Given this list of marker genes POLR3K, COQ5, MIR4512, PDCD6IP, STX16, CDKN2AIPNL, DSP-AS1, BPHL, DBNL (drebrin like), TOM1L2 (target of myb1 like 2 membrane trafficking protein), SNHG12, LARS1, ARRDC2, ZNF410 (NCBI Gene Id 57862), MRPS31P5, PLAUR, SNHG7, USP30, GRPEL2, DISC1, RPS13, ZNF391, GAP43, ZNF569, HIRA, HCG20, AGPAT3, MBLAC2 (metallo-beta-lactamase domain containing 2), POLR1HASP, DYM, EIF2B3, TOMM22, H3C9P, SREBF1, SVIL, CFAP298, MAP3K9-DT, ITGB3BP, SNHG11, UIMC1, PCOLCE2, DHX8, ST6GALNAC2, SYT14, PDZD7, LEO1, ZNF740, EIF1AD, HEXA, LGALS8-AS1, AFMID, TMED2, QRICH1, PIK3IP1-DT, SMG5, EXOC8, ZNF546 (zinc finger protein 546), BMS1P4-AGAP5, DMGDH, DENND2C, UCHL5, LINC00663, SAMD4B, ZNF165, RNVU1-6, TIMM50, ABHD12, RBL1, ENTPD1-AS1, FAAP100, SMG7, SPEF2 (NCBI Gene Id 80192), MARK4, HTR5A (5-hydroxytryptamine receptor 5A), ZNF30-AS1, HSPD1, SLC25A16, CSRNP3, UBAP2, ZNF425, OGT, SMIM10L1, MDC1, SDHAF1, SRMS, CCDC159, SCP2, SNUPN, INO80B-WBP1, RAB11A, COPA, METTL15, SIRT2, METTL17, MTOR, AP3S2, RUFY1, EIF4E2 (NCBI Gene Id 9470), KAZN, RPL37 (NCBI Gene Id 6167), ZCWPW1, WDR70, PPP2CB, H3P41, GTF3C3, APOBEC3B, CALM3, KAT7, SVOP (SV2 related protein), LINC01409, LINC00665, IGDCC4, FANCL, NCSTN, RPS7, MAP3K21, PSMB3, MRPS33, ZNF30, RNF207, ZNF408, LGALS3BP, FAM229B, TTC23L-AS1, HPGD, TIMM29, MIR762HG, INO80B (NCBI Gene Id 83444), CDK5RAP3, UBE2I, ZNF490, INKA2, ENSG00000261335, STK38L (NCBI Gene Id 23012), KRBA1, IFT80, ELF1, CRKL, ABCA15P, DAAM2, ST13, EMX2OS, CSTPP1, HAUS5-DT, ICE1, SMC4, ZNF850, SELENOH, SLC33A1, THADA, FAXDC2, PRKACA, GNB2, EXO1, GLI1 (NCBI Gene Id 2735), COX16, ELAPOR1 (endosome-lysosome associated apoptosis and autophagy regulator 1), SNRNP35, FOXP2, TCHP, LUC7L, POLR2I, ENSG00000249295, SNORD3A, PDXDC1 (NCBI Gene Id 23042), XPNPEP3 (X-prolyl aminopeptidase 3), NOLC1, KRT75, EPB41L4A-AS1, TSPEAR-AS1, GABPB2, SMAD7, NDUFC2-KCTD14, MROH8, PHRF1, HMGN4, HEXIM2, CATSPERD, GDF15, ZC3HC1 (zinc finger C3HC-type containing 1), JAKMIP2, STMP1, HSPE1-MOB4, SUGCT, LINC01970, PBK, MIR7-3, IFT56, LUC7L2, IL17RC, SCARNA2, GUCD1 (guanylyl cyclase domain containing 1), SLC29A2, WDR26, DM1-AS, ANXA2R, TCF12, ISYNA1, UBB, DUSP6, ADRA1A, RPS15, PPP1R37, RNASE4, MRPL16 (mitochondrial ribosomal protein L16), MT-TW, C12orf76, MIR7-3HG (MIR7-3 host gene), RBM28, GNPAT, OXLD1, LMAN2, RNU6-841P, MIR5188, FRA10AC1, TRAK1, ENSG00000232995, MTR, UQCC3, GINS1, ZNF568, TLCD3B, ZNF350, LIPH, ZNF557 (zinc finger protein 557), SFSWAP, NOP58, SIL1, CCDC174, MED18, TVP23B, B3GALT4, SNRPD3, TMEM202-AS1, C19orf47, KNTC1, LYPLA2, CASTOR3P, ATOSB (NCBI Gene Id 80256), RPL6, BMS1P4, UBA2, GJC1, SCAMP3, HMGXB3, SPRED2, WDR36, UBP1, ADSL, ZNF233, HRCT1, NHSL1, COMMD2, CALM1, POLR1H, TOB2, SRA1, CBR3, TOX4, TRIM41, MAP2K5, TEX38, STUM, PCLAF, ENSG00000274248, ZNF829, HLA-DPB1, CELF1, FN3KRP, SH3BP1, ANKRD13A, DENND4A, VTRNA1-1, RNA5SP21, ADAMTS6, C2CD2L, SPRED1, IGFLR1, CD8A, ZNF45-AS1, PLEKHM3, EML2, ZFP41, GPBP1L1, SDHAP3, TLCD1, EIF2D, TLK2, ZNF284, MBTPS2, GET1, GAPDHP22, RESF1, FRG1HP, PRIM1, FZD1, KRTAP9-12P, ATP5MF-PTCD1, RAD50, COPS4, ISLR2, SPTBN4, GPATCH4, MYCBP2, C6orf89, SREK1IP1, PDE6D, OBSCN-AS1, EMG1, FMC1-LUC7L2, TSC22D4, RUVBL1, PLXDC2, GFER, NFIA-AS1, ECI1, POLR3G, PIN4, CDC123, MIR4515, NCEH1, RPTOR (regulatory associated protein of MTOR complex 1), SNHG29, ZFP30, GYS1, BACE1, STX16-NPEPL1, DNLZ, GBA1, MUC1, ALDOA, PTCD1, MRPS31, ABCB9, PDCD7, LRRC49, ZFP37, NDUFB7, HSD17B6, CAPNS1, TATDN2, SLC39A3, UBE2Z, SULT2B1, BACH2, TUBE1, HMGB1, BNIP1, ST3GAL5, CORO7, TDRD7, SNRPE, DENND2B, HJV, ZNF35, ARHGAP32, SNORA13, ASCC1, PLPP6, ZMIZ1, ZSCAN25, BLOC1S2, SF3B6, ZNF45, NDUFAB1, PRR16, PTGES3, NUP107-DT, KANTR (NCBI Gene Id 102723508), CPEB1, RAB2B, RNVU1-34, MRPL30, NBDY, DHPS, TUBGCP6, HEXIM2-AS1, TSEN15, STAT2, ZNF566-AS1, GFM1, COPS7B, THAP10, DHX16 (DEAH-box helicase 16), OSGEPL1, AGFG2, PLAU, SNRNP25, RRAS, AAR2, TMEM222, ZNF570, KRTAP10-8, NEMP1, DHRS4-AS1, COX7A2, WDR11-DT, VPS36, JMJD1C, KMT2B, ELK4, VARS2, RNF185, TPBGL, ATPAF1, ZNF268, ZNF808, LASP1, DDX56, CPNE8, SNORA50C, ZNF862, MEPCE, AKT3, LINC00265 (long intergenic non-protein coding RNA 265), ICA1, TSPAN12, ISOC1, RBBP5 (NCBI Gene Id 5929), ACVRL1, TRIP4, PPP5D1P, DAP-DT, AGK, KRR1, BAK1, GOLGA3, RARS2, SNHG17, GNG4, SCAF11, SNW1, CCNC, PCBP2, TBCD, GTF3C5, GDF5, ADAMTSL4-AS1, SCGN, EXOC3L1, E2F6, SPAG7, ENSG00000249236, RHBDF1, EIF3A, SNHG4, EPCIP-AS1 (EPCIP antisense RNA 1), DNAJC25 (NCBI Gene Id 548645), SEPTIN7P1, NOXA1, HSPE1, KIAA1671, KCTD5, NABP2, PAM16, MRPS2, B3GNTL1, NUP107 (NCBI Gene Id 57122), KRTAP5-5, PPCDC (NCBI Gene Id 60490), GRB2, MTND6P4, FAM230G, BANF1, PIK3IP1, PXMP2, FOSL2, TRAPPC8, HINT3, CCDC18-AS1, LINC01719, FLOT1, CASP8, MTND5P11, HYCC2, S100A2, GAPDHP14, DOHH, ZFP14, ODAD4, ARIH1, HLA-DMA, MT1X, SNORD84, UBASH3B (ubiquitin associated and SH3 domain containing B), AQR (NCBI Gene Id 9716), LNCTSI (NCBI Gene Id 128193292), NEK2, ZBTB41, TOMM20 (translocase of outer mitochondrial membrane 20), HNRNPA1, ATP5MC2, ST7, KDM5C, KRT89P, ZFYVE9, ENSG00000258471, C16orf95-DT, CCNL1 (cyclin L1), NME1, MPG, LIN54, C19orf44, MT-CO1, STING1, PRKAB2, DNAJC6, RHOQ, EXOC2, AXDND1, TSSK6, IDI1, ORC3, NME1-NME2, SNAP47, SLX9, CIRBP, ENC1, FHL1, EPS8, CSNK1E (casein kinase 1 epsilon), NIF3L1, ENSG00000260288, GBA1LP (glucosylceramidase beta 1 like, pseudogene), NAT1, SH3YL1, TIPRL, ADNP, PSMD3 (proteasome 26S subunit, non-ATPase 3), SNORA21, OGFOD2, ZBTB40, MRPS31P4, JTB, LBHD1, LINC00339, HDAC2-AS2, STX18, YKT6, LINC01275, LINC02454, SRRT, RPL36P5, TTC33, STAT6, DCAF8, EIF3K, KIAA2013, ABHD2, NDUFA13, TMEM259, RNU6-843P, MAF1, PRKCE, RPS6KA1, TPST1, CTNNB1, TM2D1, KBTBD4, SEC16B (SEC16 homolog B, endoplasmic reticulum export factor), METTL25, DSTYK (NCBI Gene Id 353293), HNRNPD, SERTAD3, MAPK4, TMEM79, MRPL39, FOXD3-AS1, CDC73, JMY, SLC39A2, DONSON, ATP5MC3 (ATP synthase membrane subunit c locus 3), CANX, ETFBKMT, CNNM2, MRPS15, SLC7A11, HAUS5, MED23, DHX37, CSAD, DNM1L, ATAD5, MROH2A, TMCC2, ASCC2, SSBP2, DUS1L (NCBI Gene Id 64118), DLEU1, KCNJ4, TMEM101, CCDC59 (coiled-coil domain containing 59), JTB-DT, CLIP1, LAMP1, IGF1R, RPL18P10, RPL27, UBE3D, BRD2, IFNAR1, CCT6B, BAG6, CCDC144BP, CDK11A, DSP, SH2B1, NDUFV3 (NCBI Gene Id 4731), CSNK1D, TRD-AS1, LINC03067, SLC19A2, HBS1L, ARMH3, CEBPA, DCLK1, MT-TQ, ST6GALNAC6, MCM3, GSTCD, NUP133-DT, GPI, FNDC11, TRAJ31, SMIM8, BCRP2, ZNF224, ACLY, KRBA2, INO80C, RTL8B, TRAV5, TMEM242-DT, IRGQ, PRKCH, NDUFB3, ATRIP, MIR5087, CSDE1, CMPK1, ARID1A, KANSL3, OSBPL7, TRIB1 (tribbles pseudokinase 1), HNRNPU, BAG2, LZTS2, LINC02831, DR1, MAD2L1, ATG4C, BNC2, SMAD9, KICS2, BEST3, RPS29P16, MAN1C1, RNF43, ZNF74, IFI6, RNU5A-1, IPO4, CLCC1, AFF1 (NCBI Gene Id 83116), GTF2IP20, RNU5D-1, ATG5, SLC25A21, SLC22A4, FAM133B (NCBI Gene Id 257415), SPRY1, CCDC77, KDM3B, PSMC1, MYOF, WARS1, WDR37, TAX1BP1-AS1, ZNF791 (NCBI Gene Id 163049), SLC1A3, EPRS1, PPP1R8, UBC, CBR3-AS1, TNK2-AS1, CREB3L2-AS1, UBQLN4, ENPP3, UGGT1, RMND1, KDSR, TWF1P1, RGS5, SFT2D1, GNAL, SLC35B4, NCOA7, TRMT13, CFDP1, USP54, NOL7, KHDC1, DTWD1 (DTW domain containing 1), H4C8, CENPW, PRPF39-DT, TNPO2, TPI1P2, WDR25, SYBU, WRAP53, ABR, PHF12 (NCBI Gene Id 57649), RN7SL346P, UBOX5, FANCD2, CPXM2, R3HCC1, GTPBP3, ZNF609, PEX13, EXOSC3, KANSL1, MYO19, STAT3, TTC7A, TAOK1, FAM174B, RPL23, DNAJC25-GNG10, ZNHIT3, RPL36AP13, LINC01623, NUDT15, SLC44A1, GIN1, GORASP2, RBM39, TRIM52-AS1, PIGL, ENSG00000263280, ATG7 (NCBI Gene Id 105376952), TOLLIP, MLLT6, SNORD49B, ADSS2, ISG20, SHARPIN, ZNF566, ABCA4, SCAMP2, RN7SKP114, MARCHF8, LINC00910, CCDC69, SNORA16A, STX18-AS1, RNU5B-1, CYP2S1, CXCR4, PCBP3, TMEM41A, SPRYD7, RAB37, FEM1A, LINC01559, TTC23L, MAST2, VPS29, TATDN3, NDUFS3, PPIP5K2, COASY, ZNF181, MTERF4, PEMT (NCBI Gene Id 10400), UNC5B, DYNLT4, BHLHE40-AS1, GINS4, MCAT, SSTR5-AS1, ZNF282, APOA1-AS, CD81-AS1, NMNAT1, RAI14, BTBD1, TBC1D13 (TBC1 domain family member 13), DUSP14, ADRM1, PPIL3, ZNF674-AS1, ETNK1-DT, KSR2, EXD3 (NCBI Gene Id 54932), ENTPD6, CALR3, EIF2AK3, HDAC5, HP1BP3, RPA2, ABRACL, PLEKHG5, LINC02366, ARHGEF1, RCAN1, WSCD1, RINT1, SASS6, NDUFS7, MRPL1, AARS2, PCID2, BLOC1S1, RFFL, TIMM44, NEK8, GNLY, EFL1P1, SNAPC5, MSTO2P, SRSF4, RCOR3 (REST corepressor 3), HNRNPD-DT, DHRS13, MNS1, CHD3, PHGDH, SNORD118, CAAP1, MITD1, MT-ND4L, MATR3, SLC25A23, AHCYL1, DEPP1, PCCA, MIR1273C, GIHCG (NCBI Gene Id 100506844), TRIM52, VIRMA, TRAPPC9, LRP4-AS1 (NCBI Gene Id 100507401), PSMD8, DMAP1, TMCO1-AS1 (TMCO1 antisense RNA 1), LINC01431 (long intergenic non-protein coding RNA 1431), SPEF1, AHNAK, PSCA, NPHS1, CCT8, SLC12A5, FEM1C, FAM228B, YTHDF2, FBF1, FUT10, RPL39P40, HTT-AS, HSPA4, FAM117A, YBEY, ZSCAN16-AS1, WNT3, FNDC3B, MIGA1, PIM1, MCM3AP, SNORD70B, CHD8, ZBTB18, NEU1, CDC16, C1orf159, RNVU1-14, STAT1, DPP9, CUL3, EGLN2, SMAD6, CD2BP2, ZSCAN12, B4GALT3, GPR158, SSTR5, MBD6, SNORD12C, TIAL1, NADK2, RANBP2, ANAPC16, MTMR12, BSDC1, ZNF133, SEM1, SNF8, THOC1-DT, COQ8B, SRRM5, NSFL1C, TMEM267, MRPL24, ENSG00000267058, NUDT18, C22orf39, USPL1, RNVU1-31, CNPY2, GADD45A, NUDT13, BRIP1, NFYC, TCF3, ALG14, LINC01426, SPINK9, RBSN, EPHA2 (EPH receptor A2), MT-TR, LINC00938, CCAR2, METTL9, PDCD6P1 (PDCD6 pseudogene 1), UBTF, SNX3, FGF9, AKAP10, SLC6A6, ZNF404, SH3PXD2B, MEGF8 (NCBI Gene Id 90198), KIF6, LINC01182, IL2RB, TMCO1, B4GALT7, ZNF573, MYH9, NFKB2, PCBD2, USP40, ITPRIP, TFEB, PHB2, COQ10A, LINC02453, SENP2, CCDC33, JPX, ZNF793-AS1, MAPK1IP1L, LRP1B, RPS19, ZCCHC4, ZNF26, DISP1, ZNF420, RFC1, DAGLB (NCBI Gene Id 221955, diacylglycerol lipase beta), MAPK3, AVPI1, RRP1, ZNF354A, ANO8, DLL3, C18orf21, SUPT5H, RGL2, DMKN, CRYBG2, ENSG00000233017, ARHGAP18, ELF2, CHD2, MLEC, CXCL2, RPN2, ELP5, MED12L, GPX1, VPS39, ZNFX1, DDX18, LINC00111, CWC27, NAPA-AS1, RABGAP1L, CEACAM21, THOC1, BICD2, KDM1A, ZNF335, SLC39A6, TOLLIP-DT, ARHGAP1, MRPS34, RRP15, LNPEP, MRPL44, RABGAP1 (NCBI Gene Id 23637), LINC01010, SERTAD3-AS1, MRPS16, MIA, RPS17, APLP1, RWDD1, XIST, EIF2AK3-DT, RHBDD3, MT-ND4, JADE2, MIRLET7IHG, CDC25C, TIGD6, TNPO3 (NCBI Gene Id 404679), AIG1, EFCAB7, H4C2, PSMC4, S1PR2, ZFAND6, NCBP3, DRC3, INTS12, MAZ (MYC associated zinc finger protein), TXNDC15, CATSPERG, NSL1, LZIC, ZSCAN26, H2AC12, PTPA, SYNE2, CROCCP2, BARHL1, TEFM, BORCS7, ZNF10, TBC1D19, HSF2BP, ADAP2, FAM117B, CTDNEP1, CCDC88A, TMEM134, RAD9B, RRP1B, TACO1, SPAG9, CIDECP1, NUF2, VPS25, TRMU, RSRC1, WNT9B, BACH1, H3-3B, VPS39-DT, PPP6R1, POLA1, CREBL2, SLC24A1, ADGRL1, TRUB2, TMPO, SETDB2, YIPF2, STK40, KPTN, DPH1, SRP68 (NCBI Gene Id 96239), ZNF213-AS1, IER5L-AS1, ENSG00000232876, RRP12, NUP54, ZZZ3, FTCD, RPL7L1, ABCF2, TOP3B, UTP3, SRRM3, CYP2E1, ANK2, SRSF10, SYT8, SNHG33, DNAJC11, WDR4, PTPRF, FBXO27, TNFSF9, MAP3K9, MIR1302-3, MNAT1, GEMIN7, DDX39B-AS1, WTAP, UBE2T, SMARCD2 (SWI/SNF related, matrix associated, actin dependent regulator of chromatin, subfamily d, member 2), NSRP1, TAS1R1, ITGA7, RN7SL446P, PAFAH2, MTF2, NKAPP1 (NFKB activating protein pseudogene 1), PRECSIT, C11orf65, CD68, ATN1, BTBD19, TLL2, SUGT1, CYP3A5, HSD17B1-AS1, LYPD5, SBNO1, PLEKHG2, TRAF4, LRRTM3, ITGA9, AGK-DT, NOL9, NUDT5, COPB2-DT (COPB2 divergent transcript), RPL38, LINC02186, MAN2C1, G6PC3, ARMT1, CSK (NCBI Gene Id 1445), FOXJ3, CFL1P4, AKT2, ZNF212, C10orf95-AS1, AK2, DFFA, CUEDC2, CCDC137, PAXBP1, ZDHHC8, TSFM, CLK3, ZSCAN9, NLRX1, VPS13B-DT, CCDC192, PSMF1, ZNF576, CYB5R4, CDH24, SLC12A9, B3GALNT2, LINC01411, CUL4A, DNMT1, LONP2, KLRK1, LSG1, TK1, TBX18, FAAP20, NOL12, BCL2L13, FOXA1, MIR615, ATP5MF, ACP1, THRB-AS1, ERCC4, REXO4, SEC22B, MIR4519, MST1P2, ZNF382, SBK1, MIR34AHG, ZNF674, POLR3C, H1-0, ABCB10, NDUFAF1, ANGPTL7, FIGNL2-DT, GTPBP2, PROSER3, KLHL12, LINC00649, TLX1, CASP10, ETNK1, TRUB1, CIMIP6, SMC5, MIR4726, RRM1, SYAP1, RPS15AP1, SDHAF3, AP2S1, ZNF131, KLKP1, TTC4, DDX19A, ZNF793, CAPS2, ZNF790-AS1, LINC00431, GARRE1, SSBP1, TAF6, WDR24, ZFAS1, SHB, ARID2, NDUFC2, GSPT1, TOX2, SMIM12, MYPN, RN7SL521P, MRPL40, ENSG00000187185, ZNF260, ARID5B, FRAS1, NAB2, FANCI, PRPF39, SLC41A2 (solute carrier family 41 member 2), MAP4K1, WEE2-AS1, MDP1, CDX2, ENSG00000267024, FAM98B, ARID1B, KCTD10, PCCA-DT, ZNF286A (NCBI Gene Id 93513), LINC01132, RERE, LEMD2, LDLR, VPS13B, MTUS1, MTCO3P12, ZNF155, DCAF8-DT, POLI, SRSF5, EIF3F, NFX1, FIS1, DCP1A, RO60, MPLKIP, PDXK, SNORD104, SETD5, THAP1, C17orf75, LINC01547, ISL2, TLX1NB, LMNA, TP53, MIR646HG, SMG8, ABHD16A, HEXA-AS1, MIR877 (NCBI Gene Id 100126314), MTFR2, MTCYBP18, HIF1AN, PHYH, ZC3H7B, ECH1, ZNF221, GTF2H4, SF3A3, FAM227B, AURKAIP1, WDR11, PABPC1, HCG14, INO80, TMEM69, CASP7 (caspase 7), MIA-RAB4B, C2CD5, NES, LPAR1, ZNF286A-TBC1D26, N6AMT1, YJU2, NKAP, ZNF56P (zinc finger protein 56, pseudogene), LUZP1, CMC2, ARL8B, BTBD7, RPS6, MCFD2, ZSCAN23, RNVU1-21, KDELR1, HELZ, SYCP2L, IFTAP, MTIF2, COG2, PRDX3, RNVU1-15, ZNF641, SLC6A12, VIRMA-DT, DNAH2, MIR3928, TARS2, FAN1, PIGW, COPB2, TOR1AIP1, VPS51, TM9SF4, PKMYT1, ADPGK, HMGB3P22, ZNF230-DT, BORCS7-ASMT, C1orf131, CCDC63, PPM1D, SNRPB, COX20 (cytochrome c oxidase assembly factor COX20), NUP133, TGFBI, LYN, KAT6A, CREB3L4, IFT46, TIGD1, UTP14A, BMS1, ALOXE3, KBTBD7, SPRYD4, CEP89, LY6K, SPRTN, LINC02593, RAF1, KDM5A, SNHG25, EMX2, LONP1, IPP, NDC1, SH3BP2, ANKRD40, ZMYM4, SEC13, SEPTIN7P13 (septin 7 pseudogene 13), CNOT4, LINC01775, THRAP3, LGALS8, TMBIM6, C12orf43, LINC02980, ALDH1A2, IER3-AS1, TRDMT1, FAM53C, BPNT1, VDAC2, ZNF205, MICALL1, MC1R, DNAJC9-AS1, ALOX12B, CSNK2A1, WDR62, INTS2, OSGEPL1-AS1, LRRC37A3, PYCR2, SENP5, ZNF689, RARS1, DPAGT1, TUT1, ARVCF, NFE2L2, LRRC37A5P, PCM1, ALG10B, ABHD11, EFCAB2, TBCB, TOMM22-DT, DESI2, SURF6, SLC2A4, ENSG00000267260, NSG2, RPL11 (NCBI Gene Id 6135), EME2, GLUD1P3, DCP1B, GPATCH3, SCG3, PKNOX1, ANG, PSMC2, JMJD4, MFSD5, UQCC6, CHST8, RBM4B, PHLDA3, FMC1, ANAPC5, GFM2, JRK, CDC42SE1, INTS14, PRRT3-AS1, VPS72, CFAP276, CLNS1A, EIF3G, ZNF461, LINC01596, ADGRF2P, DNAJA3, VTA1, KCNJ5-AS1, ILF2, TRIM29, HIVEP1, IQGAP2, RBPJ, FASTKD5, NPLOC4, ZNF540, DOC2A (NCBI Gene Id 8448), MRPL42, TLCD4, MARS1, DCDC2B, SMUG1, CKAP5, SERP1, RABEP2, CAND2, DDX39B, CDK5RAP1, ZNF280D, RNU7-27P, NSA2, VWA7, ATF1, RHOJ, MEF2C-AS2, RNF115, CEBPA-DT, EWSR1, DCLRE1B, INTS8, NEK7, ERLIN1, UBE3B, CHRNE, NOP16, CIC, ELP2, RHOT2, RSRC2, TBX6, DZIP1L, COQ4 (coenzyme Q4), BCL6, PHB1, RPS4X, IL5, ZNF398, SMG7-AS1, USP53, DDX55, NOXO1, LHFPL5, LRP3, NRM, ZNF280B, ELMO1, SNX1, LINC01556, GINS3, CYREN, CLMP, LINC02846, C1orf35 (chromosome 1 open reading frame 35), LAMTOR2, CEP250, LIN37 (lin-37 DREAM MuvB core complex component), FBRSL1, PUS10, HSPB6, TMEM167B, CLTCL1, AP4B1, CCNT1, SUGT1-DT, RMDN1, RNASEL, TLE6, CALM2, BEND3, TXNRD1, POLE, PIERCE1, TRAJ7, ST3GAL5-AS1, LIMD1, TMEM248, CFAP298-TCP10L, FBXO17, EZH1, DDX19A-DT, TMEM242, CTR9, PFKL, CLPB, DNAJB12, NBPF1, DRAIC, FAAP24, SAC3D1, MDM2, RNVU1-27, DAND5, HCG15, ISCA1, INTS5, THOC5, POLR3B, here is a description of the gene set: from publication Yevshin I, Sharipov R, Kolmykov S, Kondrakhin Y, Kolpakov F (PMID 30445619) Human Gene Set: ZNF30_TARGET_GENES studied in species Homo sapiens Genes containing one or more binding sites for (ZNF30) in their promoter regions (TSS -1000,+100 bp) as identified by GTRD version 20.06 ChIP-seq harmonization.